Given this list of marker genes ANKH, ESR1, SLC34A1, FAM20A (FAM20A golgi associated secretory pathway pseudokinase), SLC34A3, here is a description of the gene set: An elevated level of osteocalcin in the blood. studied in species Homo sapiens Increased circulating osteocalcin level Human Gene Set: HP_INCREASED_CIRCULATING_OSTEOCALCIN_LEVEL